The following is a description of a gene set: part of: Neurotoxicity of clostridium toxins Botulinum toxin type C (botC, also known as BoNT/C) is only very rarely associated with human disease and a pathway by which it might enter the circulation from the human gut has not been described. Nevertheless, the toxin itself, a disulfide-bonded heavy chain (HC) - light chain (LC) heterodimer (“dichain”), is capable of binding to neurons by interactions with cell surface gangliosides, the bound toxin can enter synaptic vesicles and release its LC moiety into the cytosol of targeted cells, and the botC LC can cleave synaptosomal associated protein 25 (SNAP25) and syntaxin 1 (STX1) on the cytosolic face of the neuronal plasma membrane. These four events are annotated here. Reactome Pathway: Toxicity of botulinum toxin type C (botC) studied in species Homo sapiens, and this is the list of marker genes: STX1B, STX1A, SNAP25